Given this list of marker genes MT-CO1, NDUFS6 (NADH:ubiquinone oxidoreductase subunit S6), STOML2, NDUFAB1, NDUFA12, MLXIPL, NDUFA13, UQCRHL, NDUFB1, SDHC, NDUFC2, ATP5F1D, MT-ND1, UQCRC1, RHOA, BID, NDUFS5 (NCBI Gene Id 4725), COX7A1, UQCRFS1P1, ANTKMT, COX6B2, ATP5PO, MLDHR, NDUFA5, NDUFA2, NDUFV2, MT-ATP6, NDUFA8, CYCS, CCNB1, PINK1, NDUFB7, NDUFB9, SIRT3, TMEM135, ATP5F1B, ISCU, NDUFS2, COX5B, NDUFS3 (NADH:ubiquinone oxidoreductase core subunit S3), COX4I1, MT-CO3, NDUFV3, SNCA, UQCR11, COQ9, MTCH2, ATP5F1A, UQCRQ, NDUFB2, CYC1, NDUFC1, UQCC2, ETFRF1, COX8A, COX4I2, DNAJC30, COX7A2L, UQCR10, MT-ND4L, COX6A2, UQCRFS1, SLC25A23 (solute carrier family 25 member 23), COX6A1, SDHA, FXN, SLC25A33, UQCRB, GHITM, NDUFA9, COX5A, ATP5F1E, NDUFS4, NDUFA11, NDUFA7, MTCO2P12, NDUFB4, UQCRH, NDUFS7, MT-CYB, CDK1, MT-ND4, NDUFS8, AK4, SDHAF2, COX6B1, NDUFA6, NDUFB8, MACROH2A1, PARK7, ATP5IF1, MT-ND2, NDUFB6, NDUFB10, NDUFC2-KCTD14, NDUFAF1, COX7C, NDUFA4, COX7B2, SDHD, NDUFB11, ATP5PD, ATP5MG, CHCHD10, UQCRC2, ABCD1, ATPSCKMT, VCP, ATP5ME, MT-ND3, NIPSNAP2, DLD, MIR210, SHMT2, TNF, ATP5PF, COX7A2, NDUFB3, COA6, ACTN3, MT-ND5, SLC25A51, COX7B, NDUFA10 (NCBI Gene Id 4705), DNAJC15, ATP5MF, COX8C, TEFM, PPIF, DGUOK, ATP5PB, NDUFV1, BCL2L13, MSH2, ATP5F1EP2, CHCHD2, MT-ND6, NDUFA3, ATP5F1C, MT-CO2, ATP7A, COX7A2P2, SDHB, MT-ATP8 (NCBI Gene Id 4509), COX6C, C2orf69, NUPR1, NDUFS1 (NADH:ubiquinone oxidoreductase core subunit S1), NDUFA1, UQCC3, NDUFB5, here is a description of the gene set: Human Gene Set: GOBP_OXIDATIVE_PHOSPHORYLATION studied in species Homo sapiens The phosphorylation of ADP to ATP that accompanies the oxidation of a metabolite through the operation of the respiratory chain. Oxidation of compounds establishes a proton gradient across the membrane, providing the energy for ATP synthesis.